The following is a description of a gene set: Glaucoma which forms during the early years of a child's life is called developmental or congenital glaucoma. species: Homo sapiens Human Gene Set: HP_DEVELOPMENTAL_GLAUCOMA Developmental glaucoma, and this is the list of marker genes: LARGE1, POMT2, FLNA, FZD4, CYP1B1, FKRP, CANT1, RPL15, RPL31 (NCBI Gene Id 6160), RPL35A, RPL18, ATOH7, TEK, RPS20, PXDN, NCAPG2, GATA1, CHST3, RPL5, PITX2, RNASEH2A, RNASEH2B, RPS10, TREX1, GNAQ, TWIST1, FKTN, RPS29, FOXE3, SRY, ADA2, LTBP2, RNU7-1, ADAR, HEATR3, PAX6, RPL11, RPS24, RPL8, RPL27, RPL26, AKT1, RNASEH2C, IFIH1, POMT1, LMX1B, RPS7, MAB21L1, FGFR2, POMGNT1, PYCR1, MYOC, NDP, OCRL (OCRL inositol polyphosphate-5-phosphatase), RPS27, GLIS3, B3GAT3, RPS15A, LSM11, TSR2, SH3PXD2B, SAMHD1, FUT8, RPS28, ADAMTSL1, RPS19, SBF2, FOXC1, DAG1, SIX6, RPS17, RPL9, MAFA, RPL35, RPS26